The following is a description of a gene set: Any process that increases the frequency, rate or extent of cardiac muscle contraction. Mouse Gene Set: GOBP_POSITIVE_REGULATION_OF_CARDIAC_MUSCLE_CONTRACTION studied in species Mus musculus, and this is the list of marker genes: Nppa, Hsp90aa1, Kcnq1 (NCBI Gene Id 547397), Smtn, Ucn, Chga, Ccn2, Ace2, Adra1a, Rgs2